Given this list of marker genes WDR83OS, RAB5IF, NOMO1, NCLN, NOMO2, CCDC47, NOMO3, TMEM147, TMCO1, here is a description of the gene set: Human Gene Set: GOCC_MULTI_PASS_TRANSLOCON_COMPLEX species: Homo sapiens A protein complex that mediates the insertion of multi-pass transmembrane proteins into endoplasmic reticulum (ER) membrane. Substrates enter via the lateral gate of the Sec61 translocon. The complex comprises the GEL subcomplex (composed of RAB5IF/OPTI and TMCO1), the BOS subcomplex (composed of NCLN/Nicalin, NOMO and TMEM147) and the PAT subcomplex (composed of WDR83OS/Asterix and CCDC47).